Given this list of marker genes Atp7a, Tuba1a, Scyl2, Kcnq2, Dcx, Unc5d, Ulk4, Bcl6, Uqcrq, Atg7, Dclk2, Plxna3, Fgfr2, Slc4a10, Disc1, Gba1, Lypd6, Ogdh (oxoglutarate (alpha-ketoglutarate) dehydrogenase (lipoamide)), Foxg1, Zmiz1 (zinc finger, MIZ-type containing 1), here is a description of the gene set: The process in which a neuroblast or one of its progeny commits to a pyramidal neuron fate, migrates from the ventricular zone to the appropriate layer in the cortex and develops into a mature neuron. Mouse Gene Set: GOBP_PYRAMIDAL_NEURON_DIFFERENTIATION studied in species Mus musculus